Given this list of marker genes Ccl27b, Notch1, Ighg3, Cfhr2, Bpifa1, Defa39, Lgals3, Gapdhrt2, Ifnk, Kng2, Aire, Hmgn2, Pglyrp1, H2bc12, C8b, Wfdc3, Ccl9, Ccl19-ps3, Lta, Ifna2, Gimap5, Rarres2, C7, Ifna6, Mmp7, Nod2, Pglyrp4 (peptidoglycan recognition protein 4), Pglyrp3, C4bp, Defa26, Cfh, Ppl, Ccl25, Spon2, Evpl, H2-DMa, Ccl27a, Elane, Cd55, Wfdc9 (NCBI Gene Id 634940), Defa5, Reg3d, Wfdc5, Ccl8 (C-C motif chemokine ligand 8), Tslp, Mbl2, Cfhr4, Cd37, Ccl24, Pla2g1b, C1ra, Bmi1, C2, Ifng, Ccl11, Cd59a, Ccl19-ps6, H2-T23 (NCBI Gene Id 15040), Rnase6, Cd46, Cd59b, Ccl26 (C-C motif chemokine ligand 26), Ccr7, Fcgr2b, Lgals4, Spag11b, Ptpn6, Cxcl14, Gm13271, Gm13272, Ifna11, Ifnab, Leap2, Il1b, Gpr183, Sprr2a1, Ifna13, Gimap3, Il17a, Cfp, A2m (NCBI Gene Id 232345), Cd55b, Defa3, Fgb, Cd81, Cfd, Nts, Pgc, Ighe, Hamp, Ccl22, Ccl19, Ifna15, Gm5849, Slpi (secretory leukocyte peptidase inhibitor), C1rb, Gapdh-ps15, Fga, Alox5, Ifna14, Klk7, Ctsg, Ifna5, Gata6, Inhca, C1s1, Wfdc12, Serping1, Defa29, Ighg2b, Rgcc, Vsig4, Ccl21b, Defb37, Cx3cl1, Defa21, Tfeb, Adm, Wfdc18, Tnfrsf21, Fau, Wfdc16, Hamp2, Ifne, Ighg1, Ccl21d, Traf3ip2, B2m, Defa28, Ifna12, Ccl21a, Masp1, Ccl2, C3, Wfdc13, Hmgn2-ps, Trf, Cxcl9, C4b, C1qc (NCBI Gene Id 12262), Npy, Hpx, Ccl19-ps5, Ifna4, Ccl19-ps1, Il36rn, Cxcl13, Defa2, Ifnb1, Tnf, Pla2g6, Acod1, Cxcl15, Reg3g, Tfe3, Cfi (complement component factor i), Ccl1, Defa25, Wfdc17, Defa22, Reg1, Defa20, Vip, Ivl, Cfb, Ang5, Mef2c, Wfdc11, Cfhr1, C8a, Nppb, Gm13276, Ptprc, C1qb, C1qa, AY761185, Ccl21e, Ccl17, Cxcl5, Trem2, Cxcl12, Cxcl10, Notch2, Kng1, Wfdc15b, Defa34, Gapdh, Ifna1, Rps19, Wfdc21, Ang2, Wfdc2, Defb1, Rbpj, Cxcl11, Crp (C-reactive protein, pentraxin-related), Ang, Jchain, Ighg2c, C6, H2bc21, Fcer2a (Fc receptor, IgE, low affinity II, alpha polypeptide), Gata3, Il17f, Klk5, Gm13283, Defa38, Cr2, Defa17, Wfdc10, Spag11a, Ccr2, Ccl5, Colec10, Tac1, Wfdc15a, Camp, Wap, Galp, C9, Fam3a, Krt1, Defa30, Masp2, Defa24, Sh2d1a, C1rl, F2, Defa23, Ccl19-ps4, Cd5l, Ppbp, Susd4, Ifna16, Fcmr, Gm13275, Ccl4, Cstdc2, Krt6a, Pf4, Ifnz, Gapdhrt, S100a9, Fcna, Zp3, Hrg, Reg3b, Romo1, Zp3r (NCBI Gene Id 98633), Mbl1 (NCBI Gene Id 17194), Defb21, C1qbp, Bpifa5, Ifna9, Ifna7, Ang6 (NCBI Gene Id 630952), Phb1, Rnase4, Ltf, Ccl3, C1s2, C4a, Colec11, C8g, Foxj1, Ccl6, Defa31, Bpi, Dmbt1, Ighm, Exo1, Reg3a, Ccl20, Spns2, Cr1l, Defa41, Defa40, Defa42, Xcl1, Cst9, Gm13277, Reg2, Igha, Rpl39, Defa35, Hc, App, Ccl21f, Ang4, Bcl3, Defb22, Ccl7, Ppp2r3c, Ccl27al, Ccl28, Pomc, Defa37, Ccl12, Fcnb, Rpl30, here is a description of the gene set: Mouse Gene Set: GOBP_HUMORAL_IMMUNE_RESPONSE studied in species Mus musculus An immune response mediated through a body fluid.